Given this list of marker genes TRBV5-7, FCGR3B, PER1, IGLV2-11, ADAMTSL4-AS1, PI3, ANKRD13C-DT, GK3, HBEGF, ADM, G0S2, FNDC11, EREG (NCBI Gene Id 2069), NME7, CXCL8, IGKV1-16, TRGJP1, FPR3, KNDC1, here is a description of the gene set: Genes down-regulated in peripheral blood mononuclear cell 3d vs 0d in adults after exposure to Inactivated influenza vaccine, time point 3D. Comment: Down-regulated DE RNA transcripts (down >= 1.5x) shared between both TIV-vaccinated donors Systems biology is an approach to comprehensively study complex interactions within a biological system. Most published systems vaccinology studies have utilized whole blood or peripheral blood mononuclear cells (PBMC) to monitor the immune response after vaccination. Because human blood is comprised of multiple hematopoietic cell types, the potential for masking responses of under-represented cell populations is increased when analyzing whole blood or PBMC. To investigate the contribution of individual cell types to the immune response after vaccination, we established a rapid and efficient method to purify human T and B cells, natural killer (NK) cells, myeloid dendritic cells (mDC), monocytes, and neutrophils from fresh venous blood. Purified cells were fractionated and processed in a single day. RNA-Seq and quantitative shotgun proteomics were performed to determine expression profiles for each cell type prior to and after inactivated seasonal influenza vaccination. Our results show that transcriptomic and proteomic profiles generated from purified immune cells differ significantly from PBMC. Differential expression analysis for each immune cell type also shows unique transcriptomic and proteomic expression profiles as well as changing biological networks at early time points after vaccination. This cell type-specific information provides a more comprehensive approach to monitor vaccine responses. from publication Hoek KL, Samir P, Howard LM, Niu X, Prasad N, Galassie A, Liu Q, Allos TM, Floyd KA, Guo Y, Shyr Y, Levy SE, Joyce S, Edwards KM, Link AJ (PMID 25706537) Human Gene Set: HOEK_PBMC_INACTIVATED_INFLUENZA_ADULT_3DY_DN studied in species Homo sapiens